The following is a description of a gene set: Human Gene Set: MEISSNER_NPC_HCP_WITH_H3K4ME2 DNA methylation is essential for normal development and has been implicated in many pathologies including cancer. Our knowledge about the genome-wide distribution of DNA methylation, how it changes during cellular differentiation and how it relates to histone methylation and other chromatin modifications in mammals remains limited. Here we report the generation and analysis of genome-scale DNA methylation profiles at nucleotide resolution in mammalian cells. Using high-throughput reduced representation bisulphite sequencing and single-molecule-based sequencing, we generated DNA methylation maps covering most CpG islands, and a representative sampling of conserved non-coding elements, transposons and other genomic features, for mouse embryonic stem cells, embryonic-stem-cell-derived and primary neural cells, and eight other primary tissues. Several key findings emerge from the data. First, DNA methylation patterns are better correlated with histone methylation patterns than with the underlying genome sequence context. Second, methylation of CpGs are dynamic epigenetic marks that undergo extensive changes during cellular differentiation, particularly in regulatory regions outside of core promoters. Third, analysis of embryonic-stem-cell-derived and primary cells reveals that 'weak' CpG islands associated with a specific set of developmentally regulated genes undergo aberrant hypermethylation during extended proliferation in vitro, in a pattern reminiscent of that reported in some primary tumours. More generally, the results establish reduced representation bisulphite sequencing as a powerful technology for epigenetic profiling of cell populations relevant to developmental biology, cancer and regenerative medicine. species: Mus musculus from publication Meissner A, Mikkelsen TS, Gu H, Wernig M, Hanna J, Sivachenko A, Zhang X, Bernstein BE, Nusbaum C, Jaffe DB, Gnirke A, Jaenisch R, Lander ES (PMID 18600261) Genes with high-CpG-density promoters (HCP) bearing histone H3 dimethylation mark at K4 (H3K4me2) in neural precursor cells (NPC)., and this is the list of marker genes: MLXIPL, COL16A1, FAM20A, RNF144B, SLC6A4, CCDC3, LLGL2, CAMSAP3, ADAP2, PGAP2, XK, CHGB, CACNA1B, SHCBP1L (SHC binding and spindle associated 1 like), DNM1, PLAGL1, FHDC1, EPB41L3, DUSP15, TRIM65, TLCD4, SLC25A13, PTHLH, SNTA1, CCDC116, EMILIN2, ITPR3, RTL6, HTR6, DTX1, S100A11, SIDT1, NPR2, CCDC17, DNAJA4, PPP1R14A, LOX, STARD10, AIG1, ABLIM3, ADAMTSL4, PLEKHA2, SLC27A3, TPM1, LRTM2, SLC16A12, IRF8, IRX6, HTR1B, ITPKA, ANKRD35, HES3, TCEA3, CCNB2, KCNK2, SCN1B, GATA3, KIAA1755, NKX1-2, RCAN2, ARHGAP28, C2CD4C, LRRC75A, B3GNT5, HHIPL1, WDR31, GIPC3, NECAB2, ADA, ERFE (NCBI Gene Id 151176), ACSS1, PEAR1, BCORL1, UNC119, ALDH1A3, SRSF12, GPR101, OTUD7A, MT1X, GRIK4, BARX1, LMX1B, SHISA7, ZC3HAV1, MARCHF4, SLC16A9, SMAD9, FGF12, GULP1, NRK, RBP4, WNT2, CNIH2, FAM83F, HMGA1, ATP9A, SYPL2, DIRAS2, GPR150, GRHL3, LRRC3, SBSPON, TCERG1L, EPCAM, PRKG2, RAPGEFL1, SPINT2, ATP1A3, VDR, ACHE, TCF7, BCL11A, NHERF2, PARP12, NRTN, RSPO4 (R-spondin 4), MAP4K2, DPYSL4, SERTAD4, SYNGR3, LMTK2, RAP1GAP, EMP2, FCHO1, PLXDC1, ADAM23, MYO5B, DYNC1I1 (dynein cytoplasmic 1 intermediate chain 1), DUSP18, CYP46A1, ARHGDIG, KCNJ10, SEMA4B, KIF16B, RAC3, DNAJC15, SLC2A4, BRINP1, KCTD15, GAS6, FGF4, FA2H, DIPK1C, SPOCK2, GOLGA7B, NKX3-1, NFATC2, PTPRE, IKZF1, NPTX2, SLC32A1, LTK, PEX7, VIPR2, NXNL2, DLK1, LPGAT1, ARHGAP29, TTC39A, LYZL4, PLPPR4, TMEM121B, NEURL1, OSBP2, OLFM1, TMEM132D, SLC44A1 (NCBI Gene Id 63942), C19orf12, MBP, SLC1A6, LHFPL4, STK26, ROR2, DNAJC6, FZD6, GLT1D1, HAPLN4, NKX6-2, ACE, GDF7, VWA1, PDE8A, DLEU7, MATK, MFSD4A, NET1, ZFTA, DIPK1B, CGAS, KCNF1, ADAM11 (ADAM metallopeptidase domain 11), ANXA2, SLC37A1, SLC35F3, TENT5B, MN1, FGF2, TM6SF1, CDKN1C, LY6E, BMP3, EPOP, RTN1, SLIT3, MTUS2, KCNH4, BMP7, CREB3L1, LTBP4 (NCBI Gene Id 8425), FLNC, GRIK2, ELAVL2, PLD2, CEP170B, ONECUT2, PRR5, MTMR7, CD248, GRK3, SNCB, SMPDL3A, MAP7D2, GDF10, SOX1-OT, AATK (NCBI Gene Id 9625), SNX22, LIF, OLFML2B, IL17RA, SRRM4, CASD1, FMNL1, SYT6, SNAI1, PCED1B, RCSD1, ZDHHC23 (zinc finger DHHC-type palmitoyltransferase 23), ADAMTS19, AK8 (NCBI Gene Id 158067), CYRIB, PKP2, MFSD4B, B3GALT4 (NCBI Gene Id 87866), LOXL2, TC2N, PLS1, CYS1, RBFOX1, DLL3, PDLIM1, ANKRD13D, PDE4DIP, TCEA2, ZNF804A, PRIMA1, SVOP, SEMA3F, C19orf67, SEMA4D, RAB43, LGR6, GRTP1, LPAR3, BSN, TES, LY75, HSD11B2, LHX9, GPR50 (NCBI Gene Id 9248), CEBPB, ABCA2, IL13RA1, GSC, TNFSF11, H1-0 (H1.0 linker histone), NKD2, EBF2, DLX4, ARHGEF25, UCKL1, CACNA1G, ADRA1B, CLMP (NCBI Gene Id 79827), TAGLN2, TTC34, AGTRAP, AGBL4, TRNAU1AP, MAPK8IP1, CSRP1, AIFM2, HS3ST3A1, SLC37A2, KCNQ4, NMI, ADCY3, ALPL, PTPRB, PCDHAC1, GPC3, TMEM238, RAI1 (retinoic acid induced 1, NCBI Gene Id 6600), ADRA1D, KCNJ8, GRIN2D, SLC2A6, ABCB4, SLCO5A1, GNAZ, SYNC, PRRG4, HRH1, COMP, DRD4, FBXL21P, CH25H, DAPK2, ADAMTS18, NTF4, BRSK2, HOXD8, CARD10, RADIL, C16orf74 (NCBI Gene Id 404550), C8orf34, GPRIN1, KCNK6, ARVCF, CCDC184, GALNT12, AQP5, NENF, FAM241B, COL9A3, DECR1, LSR, N4BP3, LRRC3B (NCBI Gene Id 116135), RAMP2, L3MBTL1, PM20D2, RIMS1, BATF3, IL4R, PLPP2, CPLX2 (NCBI Gene Id 84242), SAMD10, PRICKLE2, MARCHF11, MGAT5B, NRIP3, PTGR2, TLL2, HPS1, CRLF1, COL12A1, C18orf21, ANK1, WNK4, MPG, SETD6, NSD1, MYO1C, COL2A1, PGF, YDJC, GALR2, MND1, MFHAS1, SHE, CHRNA7, TWIST2, EFNA2, NEXN, ACBD4 (NCBI Gene Id 79777), KCNE5, KIAA1217 (KIAA1217), AVPR1A, PACSIN1, TNFAIP8L3, SOX30, TRPM3, WTIP, SNX32, ABR, CCNA1, IL10RB, HIC1, HPS6, GAD2, SLC8A3, ALX4, WNT2B, TRIM14, BOLL, ARC, EDARADD, TRPV4, GDA, C2orf88, NMB, DYSF, SMAGP, DPP6, NSUN7, RFX2, CCDC122, AEBP1, RIMKLA, CPXM2, GPR153, FOXA2, SCUBE2, MARCHF9, SLC12A7, POPDC3, RASGRP1, YBX2, SLITRK4, TSC22D3, CELF4, INSM1, ZMAT4, RAVER2, RFTN1, NPY, USP2, CALB2, MLKL, CTSF, CBS, NFE2L3, CHD5, BTBD6, TTC9B, ITGB3, RRAD, CHRNB2, RASAL1, MARCHF10, UCP2, NNAT, SLC4A3, RHOF, PRDM8, PRRX2, GP1BB, MFSD2A, DOC2A, ESPN, PLPPR5, SPMIP4, HAS3 (NCBI Gene Id 3038), KCNB1 (potassium voltage-gated channel subfamily B member 1), TERT, COL23A1, COL18A1, PERP, ADRB2, SPOCK1, REEP2, DCAF12L1, IL7, SYT13, LRRK1, NRG3, COL25A1, CYB561 (NCBI Gene Id 1534), FBLN2, TMEM62, FGF18, COPZ2, SLC27A2, CIB2, ADAMTS5, SLC44A5 (NCBI Gene Id 204962), ELOVL2 (NCBI Gene Id 54898), TMEM151B, PITPNM3, HFM1, CREG2, CPXM1, TMEM117, ACOT12, LGI2 (leucine rich repeat LGI family member 2), PATJ, RAB37, MXRA7, GNAL, PIK3AP1, HYI, CFAP20DC, MAP7